Given this list of marker genes PLXNB3, BIRC3, PCSK5, RANBP2, FGL2, ASF1A, PIK3AP1, TBC1D1, GINM1, RNF149, WASHC4, BRWD1, PRKRIP1, PIK3CG, RPS6KA2, BCL2L1, RAD23A, CEP350, FRMD6, TBK1, KCNE1, METAP1 (NCBI Gene Id 23173), PPP2R5A, TACR2, CYP2B6, BLZF1, CHMP2A, BST2, PLAAT3, CAP2, ERO1A, TMEM243, GATAD2B, PON3, BSPRY, CLN5, COL5A1, FBXW11, DNAJC21, EPHB6, ZBTB7A, PITX3, SLFN13, RND3, TRAF5, SNRNP48, RNF2, CSF3R, HMOX1, EMC2, CLCF1, JAK2, CRLF3, RRM2B, HSPA1B, FSCN3 (NCBI Gene Id 29999), RNF34, MTHFD2, SCLY, ATP10A, SLC30A2, ATP6V0B, MX2 (MX dynamin like GTPase 2), SNTG2, CCNL1, PEX13, DTNB, MYOG, ZFAND3, PPP1R15B, NPAS2, PRRC1, ITGB1BP2, FCGR2B, HOOK2, TSSK3, LRRC59, BLOC1S4, CD14, DDHD1, CYFIP2, GRINA, SAMSN1, ZNFX1, YAE1, C19orf12, TDRD7, GAPDHS, HDAC1, ATXN7L1, GRK2, IGF2BP1 (insulin like growth factor 2 mRNA binding protein 1), CCL5, HK2, GRB2, DTX2, UBAC2, MAPKAPK2, MAFG, PROCR, NKG7, CDC42EP5, POP7, MED9, SMC5, FBXO33, IGSF6, IFNA1, STARD3, TTC39C, WDR43, FNBP4, PLCG1, PLEKHF2, PADI3, JARID2, ZDHHC20, LIF, BRWD3, PSMB9, RUSC2, DIDO1, KYAT3, RILPL1 (Rab interacting lysosomal protein like 1), GBP4, BRD3, MGAT5, F11R, OAF, CDON, GDI1, DIAPH2, SYNE2, YWHAZ, TSPAN33, CD83, NFKB1, GLRX, EVA1C, RNF19A, IGSF8, CTTN, CNOT7, SQOR, GUCD1, ARF4, KLHL25, AKNA, OSGIN2, SYPL2, SEC14L4, MITD1, MYO1E, LCT, HAT1, GNB3, SFN, CRYBG3, ARTN, CSDE1, CLDN7, BCKDHB, ABR, DNAJC1, POFUT2, PLEKHA3, PDLIM4, AP3B2, PSME3, PTPRJ, MAL, IFIT2, SLC33A1 (NCBI Gene Id 9197), CAB39L (calcium binding protein 39 like), ADAP2, TBC1D13 (TBC1 domain family member 13), LAT, NKX3-2, TMEM183A, GSR, TESK1, NFKBIA, IL17RA, DDX3Y, SGCB, MITF, MID1, MAP3K6, PRRT1, LRP8, POGLUT1, ZNG1B, ESD, AVP (arginine vasopressin), POLR2C, NDRG2, SRXN1, ZNF276, POU2F2, DENR, here is a description of the gene set: from publication Amit I, Garber M, Chevrier N, Leite AP, Donner Y, Eisenhaure T, Guttman M, Grenier JK, Li W, Zuk O, Schubert LA, Birditt B, Shay T, Goren A, Zhang X, Smith Z, Deering R, McDonald RC, Cabili M, Bernstein BE, Rinn JL, Meissner A, Root DE, Hacohen N, Regev A (PMID 19729616) studied in species Homo sapiens Genes down-regulated in comparison of control dendritic cells (DC) at 8 h versus those stimulated with Gardiquimod (TLR7 agonist) at 8 h. Human Gene Set: GSE17721_CTRL_VS_GARDIQUIMOD_8H_BMDC_DN mouse primary BMDCs were stimulated with tlr ligands and gene expression changes were profiled on Affymetrix arrays